The following is a description of a gene set: Mouse Gene Set: GOBP_NEGATIVE_REGULATION_OF_CELLULAR_COMPONENT_ORGANIZATION studied in species Mus musculus Any process that stops, prevents, or reduces the frequency, rate or extent of a process involved in the formation, arrangement of constituent parts, or disassembly of cell structures, including the plasma membrane and any external encapsulating structures such as the cell wall and cell envelope., and this is the list of marker genes: Hspg2, Higd1a, Terf1, Tnr, Xaf1, Ndc80, Map4k4, Spdl1, Fgf13, Emilin1, Smg6, Trpc5, Zfp296, Tbcd, Add2, Kdm1a, Arpc2, Pfdn6, Prap1, Bmp4, Baz1b, Bmp7 (NCBI Gene Id 12162), Inpp5k, Dleu2, Akain1, Rap1gap2, Rit2, Trim32, Bmp6, Ifi207, Ifi203-ps, Atg5, Arhgap24, Irak3, Tgfbr3, Recql4, Dnm1l, Siglece, Cbln1, Unc119, Ccp110, Cit, Apod, Fyn, Slit1, Ankrd13d, Ube3a, Stmn1 (NCBI Gene Id 16765), Cib1, Birc2, Sh3gl3, Sftpd, Ttc3, Ppfia1, Mapre1, Apoc2l, Prom2, Becn1, Aida, Tex14, Cdkl3, Efnb3, Rp1, Spc25, Lmod2, Apoc2, Ccnb1-ps, Abi3, Zw10, B2m, Cldn7, Fgfr3, Spry2, Taok1, Hrg, Syngap1, Fcgr2b, Cdk10, Gpx1, Pfn2, Ldlr, Ttbk2, Sec22b, Lif, Rufy3 (RUN and FYVE domain containing 3), Itgav, Thoc2, Pot1a, Dpysl5, Mtm1, Bcl11a, Inpp5f, Pfn1, Apoa4, Tmod1, Kmt2a, Trip13, Slc25a31, Parl (presenilin associated, rhomboid-like), Atxn7, Bbs4, Rap1gap, Fzd9, Sgk1, Kank3 (NCBI Gene Id 80880), Stmn2, Ntm, Map2, Mtbp, Twf1, Mak, Ptpn13, Lmod1, Stn1, Pafah1b1, Dpysl3, Apoc3, Cav1, Ank3, Tjp1 (NCBI Gene Id 381892), Fbxo43, Dlg4, Traf3ip1, Gsk3a, Mfn2, Prnp, Rtca, Trim31, Gsk3b, Scin, Rapgef2, Nrxn1, Hnrnpc, Clip3, Mid1, Rcc2, Ssh2, Ifi214, Ulk1, Efnb2, Carlr, Gsn, Clasp2, Diaph2, Arf6, H2-D1, Tmod3, Spock1 (sparc/osteonectin, cwcv and kazal-like domains proteoglycan 1), Wdr47, Osm, Arrb2, Fbxo5, Bcl2l2, Rab29 (RAB29, member RAS oncogene family), Slc25a5, Tom1l1, Minar1, Nlrc3, Ifrd1, Tfrc, Ryk (receptor-like tyrosine kinase), Snph, Fhod3, Lrrtm2, Runx1t1, Sema6c, Katna1 (NCBI Gene Id 23924), Arhgap4, Dennd5a, Rps6-ps4, Dusp1, Add1, Bag5, Cst3 (NCBI Gene Id 13010), Pip4p2, Lrp4, Slc35f6, Shank1, Fam107a, Plxna3, Lgals3, Tesk1, Fez1, Vdac2, Pacsin1, Cryab, Ubqln4, Clstn3, Draxin, Dusp22, Pfdn5, Nme6, Wnt3, Ptprg, Itga3, Igtp, Dab1, Incenp, Ehmt2, Cxcl10, Phldb2 (pleckstrin homology like domain, family B, member 2), Rad21, Ubqln2, Xrcc4 (NCBI Gene Id 71945), Pten, Tnfrsf1a, Rock2, Jmjd6, Sema3f, Tnfrsf1b, Dnmt3l, Abca2, Dlc1, Cbfa2t2, Setmar, Flii, Trim11, Cenpe, Knl1, L3mbtl3, Scaf8, Hspa1b, Zfp827, Fstl4, Map1b, Patl2, Fmr1, Tlr2, Anapc15, Xylt1, Tchp, Prelid1, Atg3, Cep192, Mmp14, Rbm14, Pex5, Dkk1, Pml, Cdh1, Sost, Ctc1, Tbc1d7, Fkbp4, Appl1 (adaptor protein, phosphotyrosine interaction, PH domain and leucine zipper containing 1), Dnajc15, Stxbp1, Kntc1, Tmod4, Map3k7, Xrcc3, Psmg2, Tent4b, Syt4, Trem2 (NCBI Gene Id 83433), Trim30a, Rab3ip, Dact1, Espn, Tbx6, Pik3r1, Atxn2, Gdi2, Mdm2, Rnf6, Src, Shroom2, Dmtn, Snca, Tmem39a, Pacsin2, Pif1, Capzb, Rps6ka2 (NCBI Gene Id 436439), Mkks, Camsap3, Naa10, Tmsb15l, Ankrd27, Dtnbp1, Ghitm, Trpc6, Adam17, Ppp1r9a, Vill, Cracd, Mylip, Mpv17l, Pfdn2, Cdh5, Nupr1, Park7, Bbof1, Cd38, Gclc, Ar, Dmrt1, Haspin (NCBI Gene Id 14841), Lmod3, Gas2l2, Hdac2, Id1, Rtn4rl1, Tnks2, Atrx, Tnf, Tmod2, Gorasp1, Nubp1, Trim9, Ifi208, Ptprz1, Bcl2l1, Raf1, Notch1, Gmfg, Acd, Tpr, Parp1, Esr1, Tgfb1, Rtn4, Sorl1, Specc1l, Prtn3, Met, Eml4, Fap, Lrig2, Ccr5, Smcr8, Dguok, Efna1, Dnm2, Ptprs, Acvrl1, Ulk2, Camsap2, Irgm1, Inpp5j, Fbxl2, Chadl, Rtn4r, Fxn, Bmerb1, Pgrmc1, Avil, Plk1, Mctp1, Zdhhc12, Usp44, Lpar1, Ntn1, Isl1, Bak1, Ercc4, Ikbkb, Mbp, Ppp3ca, Lmo4, Mtmr2, Frmd7, Itgb1bp1, App, Nav3, Xrcc1, Usp10, Rapgef3, Paqr3, Jam3, Ercc1, Hsf1, Cgnl1, Apc2, Trim54, Mndal, Pecam1, Igf1, Eps8, Ctnna2, Ptk2, Sox9, Ptpn9, Evl, Prkn (NCBI Gene Id 50873), Arhgap33os, Trim46, Thra, Lefty1, Fnip1, Sirt2, Mad2l1, Ccnb1, Stx1b, Ssh3, Phf2, Plscr1, Styxl1, Arhgef18, Arpin, Hip1r, Myadm, Rabgef1, Apom, Carm1, Ankrd13b, Nbn, Prkcd, Swap70, Bub3, Was, Dip2b, Tfip11, Npm1, Hspa8, Ogt, Aurkb, Mapt, Klhl22, Mad2l1bp, Dnai3, Trp53, Cptp, Psmd10, Adtrp, Sptb, Trpv4, Adcy6, H2-K1, Sema3a, Tmsb15b2 (NCBI Gene Id 100034363), Tmc8, Pcid2, Nuf2, Sacs, Mgarp, Nop53, Crbn, Ngfr, Dbn1, Wasl, Ccdc88c, Lrsam1, Itm2c, Tsku, Arhgef15, Dync1i2, Capza1, Slit2, Flcn, Ier3, Tmem182, Gas2l1, Rhpn2, Pick1, Vil1, Cdc42, Hes1, Ccnf, Nr2f1, Cd300a, Tmem14a, Dpp4, Adck1, Oma1, Bub1, Hdgfl3, Apc, Cers2, Gdi1, Nr1h3, Gfap, Pfdn4, Smarca5, Arhgap28, Rtel1, Zfy2 (NCBI Gene Id 22768), Flna, Ik, Trak2 (trafficking protein, kinesin binding 2), Cep97, F11r, Yap1, Ephb2 (Eph receptor B2), Tbc1d4, Mad1l1, Tsc1, Spef1, Pik3ca, Hmgb1, Dyrk1a, Tbc1d30, Nat10, Kif14, Snapin, Mid1ip1, Pparg, Ptpn1, Cdk5rap2, Picalm, Ch25h, Arhgap6, Mul1, Rdx, Ddx3x, Tlx2, Cyrib, Mdga1, Phf8, Spart (spartin), Tmsb4x, Snx33, Vps35, Vbp1, Coro1c, Dnaja4, Ska3, Kremen1, Kank4, Scaf4, Slx4 (NCBI Gene Id 52864), Cav3, Gen1, Robo1, Plekhh2, Pmp22, Hdac6, Grin2b, Tacstd2, Stap1, Hnrnpu, Arhgap44, Mphosph9, Tsc2, Wasf2 (NCBI Gene Id 52063), Lrp1, Rock1, Dnajb2, Odf2l, Eml2, Map1a, Atg7, Acaa2, Ngef, Arhgef2, Hgf, Togaram2, Kank2, Apoe, Mcrs1, Nlgn1, Capza2, Actr3, Samd1, Gak, Spc24, Rin3, Dnajb8, Dbnl, Cdc20, D1Pas1 (DNA segment, Chr 1, Pasteur Institute 1), Il1b, Cspg4, Smad4, Rpl13a, Pinx1, Cflar, Glce, Fat3, Vim, Hspa5, Atm, Sdcbp, Diaph3, Camsap1, Ep300, Neu3, Syt11, Csnk1a1, Carmil1, Ctnnbip1, Anxa2, Gba1, Il15ra, Luzp1, H3f3a, Limk2, Ska1, Gmfb, D130043K22Rik, S1pr1, Cdca8, Zfp365, Irgm2, Sema3g, Pfdn1, Kank1, Mt3, Itgb1, Ifi213, Mtor, Kat2a, Opa1, Prag1, Apoa2, Rhpn1, Per2 (NCBI Gene Id 18627), Nr1h4, Eif4ebp1, Birc5, Capza3, Sptan1, Wdr54, Nlgn3, Trim37, Nfatc4, Nbdy, Lmna, Snx3, Ssh1, Csk, Capg, Kif24, Capza1b (NCBI Gene Id 66747), Necab2, Ppargc1a, Antxr1, Tpx2, Slc25a4, Lcmt1, Terf2ip, Epha3, Crmp1, Exosc10, Nr1h2, Add3, Ttk, Bok, Mdm1, Chek1, Pcsk9, Cyth2 (cytohesin 2), Wapl, Cenatac, Tpm1, Dnm3 (dynamin 3), Rlf, Map6d1, Epha7 (NCBI Gene Id 13841), Sema6d, Cnn2, Zfp207, Mtpn, Scfd1 (Sec1 family domain containing 1), Neu4, Apoc1, Cfl1 (cofilin 1, non-muscle), Spta1, Prpf4b, Dcp2, Wdr44, Shank3, Itgb3, Dab2, Clec16a (C-type lectin domain family 16, member A), Dync1li1, Inppl1, Lrrk2, Arap1, Neurod2, Dnajb1, Rps6, Khdc3, Pak2, Map3k1, Capn1, Triap1, Rgma, Zwint, Rubcn, Dnajb6, Dysf, Ifi206, Ifi203, Wnt3a, Clu, Stat1, Adipoq, Twf2, Myh9, Ace, Ptprf, Ten1 (NCBI Gene Id 69535), Sptbn1, Katnb1, Diaph1, Lrpap1, Akt1, Svip, Cdk5, Nfe2, Terf2, Abca7, Arhgef7, Clasp1, Lgals1, Fgfr2, Thy1 (NCBI Gene Id 21838), Bub1b, Iqschfp, Tom1l2 (NCBI Gene Id 72936), 4930550C14Rik, Xrcc5, Efemp1, Coro1b, Lrrtm1, Tmeff2, Ckap2, Nanos2, Rhoa, Ifnb1 (interferon beta 1, fibroblast), Rad1, Scamp5, Hormad1, Prkcz, Plxnb3, Fez2, Sema4f, Apoa1, Ywhah, Pacsin3, Arfgef1, Wnt5a, Tubb4a, Acp4, Rack1, Coro2b, Epha4, Gfi1, Sema5a (sema domain, seven thrombospondin repeats (type 1 and type 1-like), transmembrane domain (TM) and short cytoplasmic domain, (semaphorin) 5A), Marchf7, Oprd1 (NCBI Gene Id 18386), Il36g, Tinf2, Mfn1, Nol3, Ankrd13a, Abhd17a, Cd300lf, Neo1, Coro1a, Bnip3, Ifi209, Tmem67, Pot1b, Avp, Prrt2, Riok3, Nrp1, Myoc, Huwe1, Phf23, Mag, Kifc1, Pink1, Gnl3l, H3f3b, Rad50, Evi5l, Ppif, Kat2b, Anapc15-ps, Lima1, Lamp2, Ptn, Carmil2, Zwilch, Hspa2, Prkcsh, Rtn4rl2 (NCBI Gene Id 269295), Mefv, Sirpa (signal-regulatory protein alpha), Psen1, Vegfa, Tnks, Svil, Cd47, Amigo3, Ccl21a, Vat1, Ptger4